The following is a description of a gene set: This event has been computationally inferred from an event that has been demonstrated in another species.<p>The inference is based on the homology mapping from PANTHER. Briefly, reactions for which all involved PhysicalEntities (in input, output and catalyst) have a mapped orthologue/paralogue (for complexes at least 75% of components must have a mapping) are inferred to the other species. part of: Integration of energy metabolism electronically inferred by orthology from the curated human pathway Reactome Pathway: Glucagon signaling in metabolic regulation studied in species Mus musculus, and this is the list of marker genes: Prkaca, Gcg, Prkar1b, Prkar2b, Gcgr, Prkacb